Given this list of marker genes FANCL (NCBI Gene Id 55120), UBE2T, BRCA2, RBM8A, FANCF, FOXF1, FANCG, GPC3, RBM10, FGFR1, MAD2L2, BRIP1 (BRCA1 interacting helicase 1), RFWD3, FANCA, GPC4, SLX4, RAD51C, GTF2H5, RAD51, FANCC, ERCC4, FANCB, FANCI, FANCD2, FANCE, BRCA1, FANCM, XRCC2, MYCN, SMAD2, PALB2, RFX6, here is a description of the gene set: Meckel's diverticulum is a congenital diverticulum located in the distal ileum. species: Homo sapiens Human Gene Set: HP_MECKEL_DIVERTICULUM Meckel diverticulum